Given this list of marker genes DAPK1, EHF, TUBB6, TRIM29, TIMP3, KCNK1, FN1, EFNB2, SLPI, TACSTD2, JAG1, FBLN1, ARID5B, PALM2AKAP2, SIRPA, GALNT3, EPB41L2, WNT5A, PTGES, COL6A2, CDA, RBPMS, CLDN4, FYN, TUBA4A, SPINT1, IL1A, PKP3, AQP3, CLU, BST2, CLDN7, SERPINE1, KYNU, EPS8, KRT17, ASAH1, GSTM3, PDGFC (NCBI Gene Id 56034), PTGER4, H2BC12, SOX9, ST14, DCBLD2, LIMA1, AKR1C1, EPCAM, TSPAN13, ESRP1, AKAP12, ARHGAP29, GLIPR1, FXYD3, CDH3, WWTR1, H2BC12L, EPAS1, ZNF22, TMEM30B, IGFBP6, LIMCH1, NNMT, MAP1B (microtubule associated protein 1B), EMP3, GJB3, AKR1C3, PLIN2, SRGN, PLAC8, DSE, CRYBG1, GNG11, RHOBTB3, KLF5, S100P, SQOR, S100A2, GJA1, ARHGDIB, GLUL, RGS20, PTGS2, TGM2, TFPI2, SMURF2, F2RL1, MT1E, PIR, GALNT14, SCNN1A, CCN1, COL18A1, KRT18, NR2F2, ITGB4, DYNLT3, OLR1, CHST15, RNF128, MSN, S100A6 (NCBI Gene Id 6277), TNFRSF21, MT1X, COL4A2, TGFBI, PPL, LAMA3, HMGA2, EFEMP1 (EGF containing fibulin extracellular matrix protein 1), TSPAN4, MTUS1, NEDD9, GRAMD2B, MT1G, RAB31, SH3YL1, CD24, GALNT1, SFN, IGF2BP2, BICC1, FGF2, ERAP2, AGR2, JUP, UGCG, TPM2, EEF1A2, PODXL, CXADR, COL4A1, MAGEA3, DKK3, SACS, VCAN, ANXA8, SLC27A2, LAD1, ARL4C, MT1F, ADIRF, CDH1, PERP, MEST, KRT7, AHNAK2, TNFAIP2, NMU, ADAMTS1, CST6, VGLL1, TM4SF1, KRT19, CXCL1, FOSL1, PLAGL1, SNAI2 (snail family transcriptional repressor 2), CSTB, MAPK13 (NCBI Gene Id 5603), LPAR1 (lysophosphatidic acid receptor 1), RAC2, CD55, MAOA, UGT1A10, MT2A, IGFBP7, GPR87, S100A4, CAPG, FKBP11 (FKBP prolyl isomerase 11), LOXL2, LGALS3, TXNIP, GATA3, MT1H, RAB25, CTSH, DTX4, IGFBP3, THBS1, FABP5, VIM (vimentin), AXL, S100A14, here is a description of the gene set: from publication Wu Y, Siadaty MS, Berens ME, Hampton GM, Theodorescu D (PMID 18724390) Genes associated with migration rate of 40 human bladder cancer cells. Human Gene Set: WU_CELL_MIGRATION studied in species Homo sapiens Cell migration is essential to cancer invasion and metastasis and is spatially and temporally integrated through transcriptionally dependent and independent mechanisms. As cell migration is studied in vitro, it is important to identify genes that both drive cell migration and are biologically relevant in promoting invasion and metastasis in patients with cancer. Here, gene expression profiling and a high-throughput cell migration system answers this question in human bladder cancer. In vitro migration rates of 40 microarray-profiled human bladder cancer cell lines were measured by radial migration assay. Genes whose expression was either directly or inversely associated with cell migration rate were identified and subsequently evaluated for their association with cancer stage in 61 patients. This analysis identified genes known to be associated with cell invasion such as versican, and novel ones, including metallothionein 1E (MT1E) and nicotinamide N-methyltransferase (NNMT), whose expression correlated positively with cancer cell migration and tumor stage. Using loss of function analysis, we show that MT1E and NNMT are necessary for cancer cell migration. These studies provide a general approach to identify the clinically relevant genes in cancer cell migration and mechanistically implicate two novel genes in this process in human bladder cancer.